Given this list of marker genes Grsf1 (NCBI Gene Id 97246), Slirp, Nsun4, Pnpt1, Lrpprc, Pde12, Supv3l1, here is a description of the gene set: Mouse Gene Set: GOBP_MITOCHONDRIAL_RNA_CATABOLIC_PROCESS species: Mus musculus The chemical reactions and pathways resulting in the breakdown of RNA transcribed from the mitochondrial genome and occurring in the mitochondrion.